Given this list of marker genes H2az1, Psmb3, Gpr132, Eif3f, Rps27a, Rpl3, Rpl31-ps12, Rpl39, H13, Plbd1, Rpl38, Ramp3, Tnip3, Smpdl3a, Vasp, Rps15a-ps6, Rpl4, Tuba4a, Ctss, Emb, Tspan13, S100a11, H2-DMb1, Gm2a, Il1b, Rps9, Plac8, Got1, Fau, Eif3h, Pgk1, H2-Ab1, Ndufa6, H2-Aa, Rpsa, Hmgb2, Psmb8, Agpat4, Psmb1, Gda, Lgals3, Napsa, Rps6 (NCBI Gene Id 20104), Gsr, Msrb1, Ifngr1, Cytip, Sem1, Eif3e, Pfdn5, S100a6, Cd209a, Sub1, Rps15a-ps4, Ezr, Pkm, Cd209d, Mgst1, Snx20, Lmnb1, Coro1a, Cebpz, Nfil3, Cd52, Eif3k (eukaryotic translation initiation factor 3, subunit K), Fxyd5, Cd47, Ndufb7, Aldoa, Rab11fip1, Tkt, Btg1, Ifitm6, C3, Gm15421, Syngr2, Tmsb10, Rpl6, Rgs2, Itgb2, Uba52, Cyba, Lmo4, Cdk2ap2, Samsn1, Srrm1 (NCBI Gene Id 99965), Tnfaip6, H2-Eb1, Prdx5, Cd74, Rab5if, Gpi1, Taldo1, Rbm3, Cks2, Myo1g, Atp5pd, Btf3, Anxa2, Anxa1, Tax1bp1, Rpl35, Nop53, Rps18, Csf2rb, Rps15a, Itgb7, Ptprc, Retnla, Cyrib, H2-DMa, Sp140, Sec11c, Mpeg1, Plp2, Ccr2, Rps28, Cd24a, Supt4a, Psap, Rps19, here is a description of the gene set: Mouse Gene Set: TABULA_MURIS_SENIS_LIMB_MUSCLE_MACROPHAGE_AGEING from publication Tabula Muris Consortium (PMID 32669714) species: Mus musculus